The following is a description of a gene set: Hairy cell leukemia (HCL) is a chronic B cell malignancy characterized by the diffuse infiltration of bone marrow and spleen by cells displaying a typical hairy morphology. However, the nature of the HCL phenotype and its relationship to normal B cells and to other lymphoma subtypes remains unclear. Using gene expression profiling, we show here that HCL displays a homogeneous pattern of gene expression, which is clearly distinct from that of other B cell non-Hodgkin lymphomas. Comparison with the gene expression profiles of purified normal B cell subpopulations, including germinal center (GC), pre-GC (naive), and post-GC (memory) B cells, shows that HCL cells are more related to memory cells, suggesting a derivation from this B cell population. Notably, when compared with memory cells, HCL cells displayed a remarkable conservation in proliferation, apoptosis, and DNA metabolism programs, whereas they appeared significantly altered in the expression of genes controlling cell adhesion and response to chemokines. Finally, these analyses have identified several genes that are specifically expressed in HCL and whose expression was confirmed at the protein level by immunocytochemical analysis of primary HCL cases. These results have biological implications relevant to the pathogenesis of this malignancy as well as clinical implications for its diagnosis and therapy. Human Gene Set: BASSO_HAIRY_CELL_LEUKEMIA_UP Genes up-regulated in hairy cell leukemia (HCL) compared with normal and other neoplastic B cell populations. studied in species Homo sapiens from publication Basso K, Liso A, Tiacci E, Benedetti R, Pulsoni A, Foa R, Di Raimondo F, Ambrosetti A, Califano A, Klein U, Dalla Favera R, Falini B (PMID 14707115), and this is the list of marker genes: PTTG1IP, TBKBP1, EPB41L2, VAMP3, MFAP5, IL3RA, GAS7, SUSD5, RPLP1, DLC1, ME3, FGF2, PRSS23, SLITRK5, DST (NCBI Gene Id 80105), SPRY2, ANXA1, CAMTA1 (NCBI Gene Id 23261), TIMP4, PTPRM, CYB5R1, CPVL, MYF6, S100A13, TACC1, ENG, LILRB2, RIN2, PLXNC1, NOVA1, BMERB1, EMP1, SMPDL3A, ADCY9, THBS1, RCBTB2, MAF, B2M, TNFRSF1A, DAPK1, AIF1, SIX3, GABARAPL2, SDC3, PHF2, RTN2, HBA1, TRIM2, TIMP1, FLT3, SYT1, CCND1, HBG1, RNF11, IL18, CTBP2, HBB, ARAP2, CD63, IGFBP3, WWTR1, HPGDS (hematopoietic prostaglandin D synthase), ARRB2, IL1R1, RAB13, MTSS1, RECK, DPYD, IL1R2, TCF7L2, FGFR1, KCTD12, HPN, ACTB, MYOF, PLOD2, TMEM59, PPIC, RRAS